Given this list of marker genes Sesn2, Tsc2, Usp7, Prkaa2, Prkacb, Tbk1, Mapk3, Ube2n, Deptor, Peli1, Itfg2, Ywhag, Sar1b, Atxn3, Tsc1, Prkaa1, Ube2d1, Depdc5, Stk11, Pten, Nprl3, Alg13, Nprl2, Kics2, Npc1, Szt2, Sesn1, Vhl, Ywhaz, Ube2w, Bmt2, Rnf152, Nlk, Castor1, Kptn, Spaar, Sar1a, Atm, Prkaca, Castor2, Ube3a, Otud7b, Tbc1d7, Sesn3, Akt1s1, Rnf167, here is a description of the gene set: Mouse Gene Set: GOBP_NEGATIVE_REGULATION_OF_TORC1_SIGNALING studied in species Mus musculus Any process that stops, prevents or reduces the frequency, rate or extent of TORC1 signaling.